The following is a description of a gene set: A process that is carried out at the cellular level which results in the assembly, arrangement of constituent parts, or disassembly of cytoskeletal structures. Human Gene Set: GOBP_CYTOSKELETON_ORGANIZATION studied in species Homo sapiens, and this is the list of marker genes: PLA2G1B, CHD3, ARHGEF26, ITPKA, TMSB10, EPB41L4A, KLHL24, BRWD3, CDK10, PRKN, S1PR2, DNAAF3, BCAR1, ABRA, MARCKSL1, TGFBR1, CCL26, PDGFA, BICD1, SLC9A1, HAUS7, SPECC1L, WRAP73, CCDC39, CEP70, PDCL2, RSPH6A, SHTN1, SAC3D1, ZW10, PIP5K1C, KRT4, DES, EPHA3, IFT56, TRAF3IP1, SETD3, SMAD4, PDXP, TLN2, NLGN1, AMOT, ANXA1 (annexin A1), APOE, SHANK1, ODAD3, CECR2, ARL2, RAC3, CCNL2, RHOU, VCP, MAST2, NCK1, ACTL6B, MYL2, SLIT2, WDPCP, ARHGAP40, KRT34, RNF19A, CNN3, DNAAF4 (dynein axonemal assembly factor 4), ROCK1, TUBG2 (tubulin gamma 2), MCPH1, CAPZA1, ZMYND12, CFAP46, TAOK1 (NCBI Gene Id 80214), SRCIN1 (SRC kinase signaling inhibitor 1), KRT23, EML4, ARHGEF10L, NEDD1, IQGAP2, GMFB (NCBI Gene Id 2764), LIMK1, TUBB2B, MARK4, MID1IP1, DRC1, CDC20, TTLL13, MRTFA, MARCKS, CCDC68, KANK3, BBS4, TBCE, STMN4, KIF2B, NEXN, DAPK3, GAN, KRT26 (NCBI Gene Id 353288), ERBIN, FGD4, LRRC61, CHEK2 (NCBI Gene Id 11200), ATXN7, CEP152, CDC14B, CCDC88C (coiled-coil domain containing 88C), ARPC5, ARPIN, KRT18, FLII, MDM1, RIPOR2 (NCBI Gene Id 9750), DCHS1, CFAP206, BST1, CYRIA (CYFIP related Rac1 interactor A), KRT27, ATRX, INPP5K, DOCK2, CHMP5, CRIPT, RASA1, NAV3, TUBAL3, MYO6, SPTBN4, ESPL1, CCDC102B, TUBA3C, KIF24, ANKFN1, KRT83, NDE1, RNF4, MTOR, VASP, MYOM1, SRC, SRGAP2, CLRN1, BCR, FSCN3, MKLN1, BORA, VIM, POC5, AUTS2, CDC42BPB, ACTN1, KRT76, TUBA3D (tubulin alpha 3d), PPP2CB, MYLK3, SIPA1, PTK2B, RCC1, MAST4, MET, CORO1A, IQSEC1, ASPM, HOATZ, SPTBN1, ARHGEF19, NLRP5, FIGNL2, STARD13, CCNB2, CEP20, PKP1, DST (dystonin), TACSTD2, ARHGEF17, GPM6B, CASQ1, SEMA5A, DNAI3, C9orf72, TTLL6, KLHL20, WTIP, LIMD1, MAP1S, SKA1, CLIP1 (NCBI Gene Id 6249), FIGN, CDK11B, MAP10, SOX9, NDEL1, KATNB1, CKAP5, CDC42EP1 (CDC42 effector protein 1), TAGLN3, TNKS, TESK1, HCLS1 (hematopoietic cell-specific Lyn substrate 1), SLK, CLIP2, SRF, TRIM32, APC, POTEF (POTE ankyrin domain family member F), POC1A, NME7, ATF5, KRT1 (keratin 1), FGD3, KIF19, CDC42, CALD1, PTPN1, FERMT2, KRT82, KIFBP, TTK, PDLIM1, ELMO1, ACTN2, TBCEL, LMNB2, ANG, SAPCD2, WDR90, DNAAF8, ITGB1BP1, INA, NINL, BCL2L10, PIK3CA, PPP2R3C, FER, AMOTL1, MIR149, SNX9, CFAP410, EPS8, PAFAH1B1, HIP1R, FSD1, SPAG17, RALA, FGD5, GOLGA2, KAT2A, HEPACAM2, SH2B2, HLA-DRB1, PAK3, DIAPH2, RHOV, PARD6B, BMP10, MDK, CLASP1, KIF3B, STK36, FAM110A, MYO18A, KRT75, DLC1, CFAP157, MYADM, DNAJB13, CAMSAP2, DSP (desmoplakin), PLS1, CATIP, CEP68, STMN2, CCNL1, CCDC78, CSF1R, DNAAF10, VPS54, CXCL1, CTNNA2, DYRK1A, NECTIN2, SYNE3, CEP63, RGS14, ZYX, FGD1, CIB1, ATP2C1, MAPRE3 (microtubule associated protein RP/EB family member 3), KCTD13, CDK11A, MTM1, NUSAP1, PACSIN1, PHACTR4, GFAP, ANK3, MIR335, PAK2, TRIP10, PRKAA2 (NCBI Gene Id 5563, protein kinase AMP-activated catalytic subunit alpha 2), DNAJB6, DOCK7, TRIM27, ATAT1, DNAAF5, ARPC2, HAUS4, NPHP4, UXT, OPHN1, PPL, LMOD2 (leiomodin 2), CYLC1, ODAD4, LRRC46, NSFL1C, CCL11, CHP1, DZIP1, APC2, CFL1, DEUP1 (deuterosome assembly protein 1), TTC8, TBCB (NCBI Gene Id 126386), NEBL, P2RX7, MYH9, PDCD6IP, BRAF, ATP8A2, FLNC, DNAH17, PRC1, SENP6, TPM1, RND3, RND2, TUBB4A, HAUS5, RND1, PRKCZ, CEP126, SPAG16, MYO5A, OFD1, STMND1, WIPF1, SS18, VIL1, CEP19, WDR62, MTPN, TUBB2A, PRKCE, BBLN, WEE1, SEMA6A, FHL3, KIF4A, CAPN2 (NCBI Gene Id 824), CCL24, TRIM37, FRMD7, USH1C, CEP250, HDGFL3, KHDC3L, TUBG1, HAUS6, HAUS8, WHAMM, CHMP4B, KIRREL1, CIT, CFAP73, ACTL7B, TUBA4A, WAS, CNN2, AGAP2, DPYSL3, ABLIM2, DNAI2, PHPT1, AKAP11, TJP1, ARHGEF2, FGF13, GABARAP, CROCC, PHACTR3, MIR143, MAP3K20, MEIG1, ZEB2, INCENP, SPAG1, CAPZA3, BCCIP, IQSEC2, MARK3, ZPR1, F2RL1, RTTN, RANGRF, CORO6, TLE6, FBXW11, TGFB2, WNT4 (Wnt family member 4), SHROOM3, ARPC3, INPP5J, SHROOM2, SFRP1, CARMIL3, PTEN, PSRC1 (NCBI Gene Id 96740), MYBL2, ESPNL, SUGT1, ARPC1A, ABL2, CRYAB, NEB, NCKAP5, KRT78, CAPG, HMCN1, EML1, PCNT, SPIRE1, KAT2B, CORO1B, ARFIP1, FHDC1, KIF21A, CHMP4A, KRT79, SHANK3, PARD6A, ARRB1, BAG4, PARP3, GHSR, PIERCE1, AUNIP, FRMD5, BIN3, LCP1, DYNC1H1, PDLIM4, MYBPC3, PHACTR1, RAB6C, RHPN2P1, BFSP2, LIMD2, KRT81, GRHL3, F11R, GEN1, KATNBL1, CNTROB, GDPD2, FSCN1, PHLDB2, KRT25 (NCBI Gene Id 147183), INF2, PRKCI, CLIC4, CCDC6, PKD2, FOXJ1, BAIAP2L2, ARPC5L, EVPL, KRT80, GSK3B, PCM1, WASHC3, PPP1R9A, AMOTL2, COBL, VPS4A, NF2, USP33 (ubiquitin specific peptidase 33), NPHS2, ADD1, CAVIN3, TUBB6, TEKT2, CDH5, SGO1, TPM2, PAK4, CCDC63, AGFG1, RHOBTB1, CLTC, SIX4, ULK4, AGFG2, IQGAP3, HOOK2, KIF18A, S100A9, SPRY1, NGEF, ACTL7A, DIAPH3, CGN, GAS2L2, RGS4, LRRC23, RAB13, TTLL8, PHACTR2, LMOD3, SRGAP2C, NRP1, TRPM2, TNNT1, TMSB15C, PRKAR1A, TTC12, ZRANB1, ASAP3, TPR, TMEFF2, ENAH, PACSIN3, STMN1 (stathmin 1), PTGER4, TUBA1B, RHOBTB2, DMD, ENKD1, MAEA, TMSB4X, KRAS, CAPN10, PLS3, ARF6, GIT1, ABI2, TTC17, CCDC8, PAK5, GAS2L1 (growth arrest specific 2 like 1), DBN1, STARD8, PLK3, LORICRIN, KANK2, CDK2AP2, KIZ, CEP135, PAK6, TENM1, CALR, CCDC146, RAC2, ALOX15, DISC1, MAST1, AP1AR, SDCBP, SIRT1, TPM3, CYFIP2, EFHC1, ADD3, TGFB1, MYH6, PALM, CCR7, TRIM54, CORO1C, STMN3, FLNA, CDKN1B, LMNA, ARPC4, HRAS, NEFL, SNUPN, MIR214 (NCBI Gene Id 406996), TUBA4B, ARHGEF18, BAIAP2L1, SPATA4, RHOH, DSG3, ATXN3, FMNL1, RSPH4A, DNAH5, DNAI1, PKD1, KPTN, CHMP4BP1, FAT1, NUP62, MYOM3 (myomesin 3), THSD7A, DPYSL2, KRT31, MYO19, SORBS2, ABI3, PLK4, DNAAF2, EZR, SH3GL2, SWAP70, EPB41L1, MARK2, POTEKP, HSP90B1, EML3, MYO1B, PPM1F, KRT9, KRT19, GAPDH, MAP7, TUBB3 (NCBI Gene Id 94749), CSRP2, IQCG, CCL3, CDC42EP3, SORBS1, SYNPO2L, MIR21, ADRA2A, POTEI, COTL1, PHIP, HNRNPU, BST2, AAAS, ITGB5, CAPZA2, TMOD3 (tropomodulin 3), SSX2IP, MNS1, KCNC3, CLIP3, WASHC2A, EPB41L2 (NCBI Gene Id 2037), ITGB1BP2, BCL2, CHMP2A, ANLN, CLUAP1, MAP2, RHO, CLDN3, CFAP65, OBSCN, TTLL5, KRT5, NPHP1, GBA2, FCHSD1, KRT32, JAK2, CDCA8, CSRP3, NEURL1, TTLL4, WIPF3, PLXNA3, KIF14, GRB2, SNCA, MYOZ2, MISP, RP1, AQP5-AS1, FMNL3, ARHGEF28, TNXB, CRACD, ARHGEF15, CALML5 (calmodulin like 5), ESAM, FBXW5, SHC1, DCTN6, HRG, CFL2, DAW1, SDCCAG8, PRKG1, CX3CL1, MRAS, EEF2K (NCBI Gene Id 29904), ARF1, KRT7, KRT16, PPFIA1, BCL6, CALML4 (calmodulin like 4), PPP2R1B, CHMP4C, SPAST, CENPA, DAAM2, NCOR1, KRT14 (keratin 14), AQP2, ARHGAP44, DVL3, TBCK, RHOA, S100A10, CYRIB (CYFIP related Rac1 interactor B), TTLL3, SOD1, KRT6A, FGF10, KRT40, YEATS4, SSH2 (NCBI Gene Id 85464), BMERB1, SVIL, NUAK2, DVL2, PPFIBP1, RAB11A, NDC80, DIXDC1, PEX14, WASF1, FLNB, ALKBH4, SSH1, PKP3 (NCBI Gene Id 11187), ODAD1, STRIP2, UBE2B, KRT72, KAT5, PDLIM5, FBXO24, TWF1, ARHGAP4, TMOD4, FHOD1, KRT28, PLK5, ABLIM3, CEP131, FKBP4, TTLL2, TPPP3, CCDC61, WASF2, ASB2, KIF25, CDC14A, RHOG, EFNA5 (NCBI Gene Id 1946), NUDC, TPPP2, ARFGEF1, DYNC1LI1, KLHL1, RAN (NCBI Gene Id 87046), MYO15A, PIK3R2, PRPF40A, TCAP, KRT86, MYCBP2, DBNL, KRT73, CCDC40, IQGAP1, DNAH2, XIRP2, RAE1, PREX1, MAPKAP1, TUBE1, TTLL9, CEP192 (NCBI Gene Id 84082), TSPAN32, DNAAF6, PPP1R9B, CEP43, CAP2, CFAP97D1, AFG2B, KRT2, PKP2, DCTN1, PRKD1, TUBB8, MAPT, TMSB4Y, MAP7D2, SPEF1, PEAK3, FHOD3, PIN1, ARHGEF7, SASS6, HTT, NAA25, SMC3 (structural maintenance of chromosomes 3), CEP44, ITGB3, TWF2, CETN2, NCKAP5L, WDR47, CGNL1, TUBGCP2, SLAIN1, GNAI1, AVIL, MAP6, CDC42EP5, TLN1, RAC1, DYNLT1, MAP1A, WDR1, CHMP1B, KRT38, RHPN1, CAV3, VPS4B, KRT6C, TSC1 (NCBI Gene Id 7248), CFAP44, EVL, THY1, SCIN, KIAA0753, AURKA, KIF23, ODAD2, CCDC88A (NCBI Gene Id 731560), TNFAIP3, PDPK1, OBSL1, CXADR, KIF15, GPSM2, NCK2, PARVB, SHH, TNNT2, ADPRHL1, KRT74, SPACA9, SPC25, TUBGCP6, MAPRE1 (NCBI Gene Id 22919), LIMA1, EMP2, CDK2, XIRP1, CSNK1A1, TAGLN2, INPPL1, MYH14, XRCC2 (NCBI Gene Id 7516), XRCC3, TUBB4B, CCDC13, SIPA1L3, MAGEL2, WASH6P, SAMD14, AIF1L, MICALL2, CLDN19, KIF3A, CCSAP, SPTBN2, CYLC2, OAZ3, NEK7, RHOQ, TUBGCP4, ANK1, ZMYM6, POLDIP2, LMOD1, SLAIN2, ANK2, MLST8, MAP7D1, FZD10, KRT15, PDE4DIP, PRUNE1, TUBA1C, CAMSAP3, ECT2 (NCBI Gene Id 55710), ABI1, PDLIM2, BCAS3, NTMT1, ANKRD23, SLC4A2, CFAP58, CETN3, CDC42BPA, KANK4, C2CD3 (C2 domain containing 3 centriole elongation regulator), GSK3A, EPPK1, CCDC65, TESK2, TUBA3E, SEPTIN1, FAM83H, S1PR1, SPRY2, CC2D2A, FITM2, PICK1, POC1B, CYTH2, TMOD1, TAOK2, RICTOR, KISS1, SYNE2, CHMP6, TRIM36, MYH3, MYBPC1, LARP4, RANBP9, FAM107A, S100A8, RMDN1 (regulator of microtubule dynamics 1), CFLAR, CCDC170, PLK2, SIPA1L1, CHORDC1, ACTG1, MYO1F, RTKN, PTK2, PCLAF, NES, MTCL1, EVPLL, PAX6, MIR20A, KIFC1, INSRR, PROX1 (NCBI Gene Id 5629), RUFY3, KRT12, MAP9, TRIM46, KRT20, NEK2, BBOF1, STAG2, PIP5K1A, PLK1, ACTR2, RSPH9, PFN1, WASHC4, PRPH, C15orf62, KRT17, APOA1, CFAP57, LPAR1, SPTBN5, AURKC, LLGL1, BIN1, GJA1, CDK5, RHOC, ATF2 (NCBI Gene Id 1386), HOOK1, KIF2A, BLOC1S6, NRAP, TRIOBP, TUBB, CUL9, MYO5C, CCL13, DNAH8, BICD2, FARP1, NOS1AP, EPB41, FMN2, MAP7D3, GAS8, FTCD, SSNA1, CETN1, PDLIM7, FGF7, MYO3B, PPM1E, MYO1C, DTNBP1, RP1L1, CDK5R1, KIF2C, NKX2-5, CFAP47, TTBK2, CAPN3 (NCBI Gene Id 825), MYH11 (NCBI Gene Id 4629), SSH3, CSPG5, THSD7B, KIT, CENPJ, MAP4, PHLDB1, ACTA1 (actin alpha 1, skeletal muscle), TPX2, SPATA7, ESPN, DNAH1, PRICKLE1, TNFAIP1, DAAM1, CAPZB, ARAP1, EML2, KRT85, WASHC1, NUMA1, BBS1, SMAD3, INO80, WNT3A, TUBGCP3, CEP295NL, SPEF2, DRC7 (dynein regulatory complex subunit 7), SKA2, MOS, CCN2, HAX1, LIMCH1 (LIM and calponin homology domains 1), ERMN, BRWD1, CLN3, RAP2A, CAPN6, SH3D19, ILK, CRK, TBC1D21, CDK5RAP2, MYBPC2, CORO7, SUN1, PFN3, PFN2, DNAAF11, MYOC, NIN, BRK1, SPIRE2, CNTN2, CFAP100, MAP6D1, CHMP2B, SMIM22, AKAP13, KRT37, CHMP3, MYPN, ROCK2, CNN1, CDC14C, DNAH7, MID1, EPB42, KRT36, TMEM67, ZNF135, KRT33A, SETD2, PTK7, FAM171A1, ACTN3, SEPTIN9, KIF18B, FARP2, JHY, WASHC2C, PARD3, SPICE1, CCNB1, SH3D21, UVRAG, CUL3, OR2A4, OCLN, MYO1H, NAV1, CEP350, TRPV4, KANK1 (KN motif and ankyrin repeat domains 1), CNTNAP1, MEF2A, PYCARD, CSAG1, WASF3, BCAS2, TOR1A, MYO7A (myosin VIIA), GHRL, SPAG6, PALLD, TBCD, ARAP3, SKA3, NAA20, TTLL1, TUBD1, CLASP2, DCAF13, LSM14A, PLEKHH2, NEFH, KRT84, NHERF1, MYO1D, SHROOM4, KNSTRN, WASH3P, ARPC1B, TRPV3, MIR138-1, KATNAL1, TMOD2, PALM2AKAP2, PDCL3, KIF20A, MAD2L1, SPDL1, PDGFRA, DLGAP5, CYFIP1, SPATC1L, CDC42BPG, GPSM1, STRIP1, HOOK3, EPB41L5, MTSS1, ABLIM1, ODAM, ARHGAP25, BAIAP2, SH3BP1, IQCA1L, FES, NAT10, MICAL2 (NCBI Gene Id 9645), CCDC57, EFCAB11, TTLL11, RGCC, IQCJ-SCHIP1, LLGL2, WDR73, HYDIN, RFLNA, LIMK2, HDAC3 (histone deacetylase 3), MAPK1, DVL1, C10orf90, CARMIL2, CCSER2, RANBP10, PARVA, NUF2, RHOJ, MAPK3, HAUS1, MYO5B, ELMO3, TACC3, RHPN2, ZMYM4, MINK1, DCX, CCL7, DNAI4, TMSB15B, LDB3, EDN1, UGT8, ARAP2, E2F4, DIAPH1, MAPK15, UBXN2B, CTNNB1, KRT35, NEDD9, ABITRAM, CCL2, CLXN, ARHGAP35, SBDS, NCKAP1, FSIP2, MAST3, MAD2L2, GTF2B, KRT3, CLIP4, XPO1, DNAAF1, BRCA1, AJUBA, LRGUK, LATS1, MZT1, MYOZ1, ARHGEF10, GAS2L3 (growth arrest specific 2 like 3), CCDC103 (NCBI Gene Id 388389), AURKB, ABRAXAS2, KRT33B, OOEP, DNAL1, CPNE6 (NCBI Gene Id 9362), CELSR1, GCC2, DNM2, JAM3 (junctional adhesion molecule 3), GAS2, ACTC1, CAMSAP1, PAK1, BRCA2, CCDC120, CLN8, ACTR3 (actin related protein 3), ELN, NF1, RPS3, PPP1R12A, FMN1, PDCD10, GPR65, BLOC1S2, CCDC69 (NCBI Gene Id 26112), PGM5 (NCBI Gene Id 5239), KLHL41, RHOD, SPTA1, PPP1R35, ARFIP2, PTPA, IFT172, MYO1G, CEP72, ALDOA, DYNC1LI2, SPECC1, FRMD3, KBTBD13, HCK, LARGE1, CDC42EP2, PPP2CA, PIERCE2, BRSK1, PRICKLE4, PARD3B, SYNPO2, SUN2, KASH5, CARMIL1, CKAP2, IQCA1, DRG1, CCDC88B, PCLO, POF1B, PLEKHG2, PKHD1, SIGLEC15, NISCH, SPTAN1, CNTLN, CFAP74, KRT6B, SON, STAG1, DCLK2 (doublecortin like kinase 2), KRT13, PACSIN2, FGD6, ARHGAP18, KRT39, CHMP1A, PRKAA1 (protein kinase AMP-activated catalytic subunit alpha 1), CCDC187, FMNL2, MYBPH, ABRAXAS1, CCP110, CCDC42, KRT77, ARHGAP17, ARHGEF5, CENATAC, KPNB1, ANKRD53, TNIK, NAA80, ARHGAP12, ANKRD1, PDLIM3, NPM1, ARHGAP28, FGD2, KRT24 (NCBI Gene Id 54481, keratin 24), MYH10, ANTXR1, ACTN4, RAP1GDS1, CENPH, CSF3, SHROOM1, TMSB15A, MICAL3, EPHA1, FCHSD2, SYNPO, TUBB8B, MYL9, KATNA1, PLA2G3, CSNK1D, CUL7, RACGAP1, SDC4, ZMYM3, TOGARAM1, PIBF1, RBM14, TOGARAM2, MLH1, MIR1-1, ARHGEF11, TGFB3, MACF1, RHOF, EHD2, HAUS2, PIK3R1 (phosphoinositide-3-kinase regulatory subunit 1), TRPM7, BNIP2, ACTBL2, DLG1, TACC1, TPM4, WASHC5, PDZD8, BIRC5, AQP1, SORBS3, HSPA1B, RAPGEF3, NPHS1, RANBP1, CCDC66, PRR5, KLHL17, RFLNB, GADD45A, MYO18B, FIGNL1, TCHH, CEP97, AKAP9, LRP1, LRCH3, CEP85, PRKCD, HAUS3, PLEC, DAG1, TRDN, PAWR, MECP2, TUBGCP5, FSCN2, CFAP43, POTEE, CD47, POTEJ, PLD2, BFSP1, SPTB, CCNF, MIR145, CAP1, STARD9, MARK1, EPHA5, CEP76, MAP1B, PFDN2, CEP295, ZNF207, CSRP1, TNNT3 (troponin T3, fast skeletal type), ARHGEF16, DDB1, CD2AP, CDC42EP4, MAPRE2, KIAA1614, TUBB1, NEK6, MYO7B, HSPA1A, MYO1E, LUZP1, EPB41L3, EPB41L4B, ARC, PADI6, CXCL12, KRT10, ZBED3, CDK5R2, KIF4B, GSN, CYLD, ACTL8, MSRB2, PDGFRB, RNH1, STIL, ARHGAP26, GMFG, SLC16A1, SH3KBP1, TAC1, SH3BGRL3, RDX, MYO3A, NUBP1, ARHGAP6, SPAG5, JMY, MSRB1, CCDC15, SMC1A, PLEK2, TUBA1A, CDK1, HIP1, TPPP, ADD2, VANGL2, VILL, PARVG, AIF1 (allograft inflammatory factor 1), TYROBP, STAU2, MKKS, TXNDC9, CHMP7, ITGB1, CALML6, ARHGAP10, CEP120, ABL1, TACR1, TTLL7, GPR35, NEFM, PARD6G, INTS13, CPLANE2, CCL21, BBS2, SYDE1 (synapse defective Rho GTPase homolog 1), MCIDAS, CFAP69, CHEK1, PLXNB1, ELMOD3, ZMYND10, TIMD4, PLEK (NCBI Gene Id 5341), ALMS1, RAF1, CRYAA, HDAC6, TUBA8, FBXO5, AXIN1, KATNAL2, DSTN, CORO2B, SIK3, CTTN, SLC39A12, LZTS2, KIF11, AGRN, TTL, SERPINF2, PXN, BRSK2, CENPE, TPGS1, MICAL1, MYOM2, MYO1A, ODF2, TACC2, ELMO2, MSN, DCTN2, ARMC2, NCKIPSD, UHRF1, TTN, PPP2R1A, LMNB1, RSPH1, IQSEC3, WASL, CFAP91, DMTN, KRT71, ACTB, SYNM, NCKAP1L, RHOB, CDC20B